The following is a description of a gene set: Mouse Gene Set: GOBP_NEGATIVE_REGULATION_OF_STEROID_METABOLIC_PROCESS Any process that stops, prevents, or reduces the frequency, rate or extent of the chemical reactions and pathways involving steroids. studied in species Mus musculus, and this is the list of marker genes: Nfkb1, 3110082I17Rik, Snai2, Dkk3, Idi2, Malrd1, Abca2, Snai1, Bmp5, Pde8b, Insig2, Sod1, Bmp2, Hrh1, Cyp27b1, Gfi1, Dkkl1, Apoe, Insig1, Erlin2, Rest, Ggcx, Wnt4, Erlin1 (ER lipid raft associated 1), Nr0b1, Ch25h, Fgf15 (NCBI Gene Id 14170), Atp1a1, Prox1